Given this list of marker genes Lyg2, Lyzl6, Lyz2, Lyg1, Lyz3, Spaca5, Lalba, Lyzl1, Lyz1, Lyzl4, Spaca3, here is a description of the gene set: studied in species Mus musculus Catalysis of the hydrolysis of the beta-(1->4) linkages between N-acetylmuramic acid and N-acetyl-D-glucosamine residues in a peptidoglycan. Mouse Gene Set: GOMF_LYSOZYME_ACTIVITY